The following is a description of a gene set: Enables the transfer of L-proline from one side of a membrane to the other. L-proline is pyrrolidine-2-carboxylic acid. studied in species Mus musculus Mouse Gene Set: GOMF_L_PROLINE_TRANSMEMBRANE_TRANSPORTER_ACTIVITY, and this is the list of marker genes: Slc6a20a, Slc6a7, Slc36a3, Slc1a4, Slc36a2, Slc36a1, Slc6a20b, Slc36a4